Given this list of marker genes CYP3A4, BCOR, PCYT1A, SMOC1, ZBTB20, UFSP2, CTC1, ADGRV1, GNPTG, POLRMT, COL11A1, BMPR1B, ALG12, DNAJC30, GTF2IRD2, MAGEL2, KIF7, AFF4, CHD7, MAP2K2, PWAR1 (NCBI Gene Id 8122), IFT172, TMEM270, SLC29A3, KIF22, NEPRO, RSPRY1, GAN (NCBI Gene Id 8139), TBL2, GORAB, TRAPPC2, SCN1B, ARSK, DMP1, SCN9A, PITX1, NOTCH2, PDGFRB, AFF3, SF3B2, TAF4, GTF2IRD1, KDELR2, CDC45, TAPT1, SLC34A3, CYP2R1, MMP13, SF3B4, FZD2, CHST3, LMOD3, CFL2, LRP5, EIF2AK3, CEP120, NEK1, NF1, CBS, SLC34A1, IPO8, H3-3B, PEPD, ORC1, MEG3, B3GAT3, RMRP, COL9A3, CANT1, ARCN1, KAT6A, IDUA, BMP4, CCDC47, AMER1, DYNC2I1, TTI1, TONSL, COL9A1, NSD1, GTF2I, WDR62, TNFSF11, CYP27B1, DDRGK1, PTH1R, LMX1B, SFRP4, OCRL, TBX15, ALPL, ANAPC1, EIF4H, PUS3, MET, NCF1, TRPV4, PDE4D, NKX3-2, STX1B, CRTAP, BRF1, COL1A1, FLNB, PRKG2, HEATR3, TRIP11, VPS13B, PLOD2, KLHL41, SPART, ZEB2, MTAP, SATB2, MEGF8, INPPL1, ZPR1, RTL1, RNU4ATAC, EN1, LTBP1, GABRA1, BAZ1B, ATP7A, KRAS, SERPINH1, SEMA3E, MAN2B1 (mannosidase alpha class 2B member 1), P3H1, TUBB3, SPTBN1, PWRN1, XYLT1, RAD21, FBN1, TMEM38B, SNORD116-1, FIBP, PRRT2, DYM, FGFR3, IFIH1, TGFB1, CCN2, NDUFAF6, GLI3, RB1, NPAP1, SLC10A7, SNORD115-1 (NCBI Gene Id 338433), ARSB, BGN, BUD23, TGDS, TNFRSF11B, ENPP1, COL10A1, DLK1, IFT57, IDH2, TBXAS1, CLCN5, CYP19A1, DDX6, GDF5, SLC35D1, VPS37D, PRKACB, TNFRSF11A, GABRD, TP53, PCDH19, GLI1, CPLANE1, PRR12, LIMK1, ACTB, B3GALT6, MBTPS2, DONSON, RFC2, GLB1 (NCBI Gene Id 2720), COG5, COL9A2, EXT1, NEK9, SLC26A2, GUSB, HYLS1, TPM2, INTU, ATR, LMBR1, RAB33B, DDR2, EVC2, SKI, TRPV6, EIF4A3, ELN, PLAAT3, TENT5A, UGP2, LBR, TRPS1, PHEX, TBC1D7, PAPSS2, CBFB, IHH, PCNT, BHLHA9, IARS2, SGMS2, DYNC2H1, LAMA5, HS6ST1, NANS, AIFM1, HCN1, SCN2A, RBM8A, SOX9, MTX2, IFT122, MPZ, COG4, PAPPA2, COL1A2, ADNP, HSPG2, CLCN7, ORC6, SHH, COL2A1, GALNS, CTNS, SP7, ZSWIM6, BPNT2, GABRG2, SLCO2A1, SCARF2, NEB, SETBP1, CAMK2A, EFL1, MCTP2, COMP, RPL13 (NCBI Gene Id 6137), LONP1, MAP2K1, GPX4, NAA60, ZNF699, SLC35A2, POLR3A, MKRN3, FN1, POLR1A, RECQL4, DYNC2LI1, GPC6, WNT7A, CCN6, CSGALNACT1, CLIP2, CILK1, TCTN3, CTCF, HS2ST1, FGFR2, CHEK2, RPGRIP1L, MATN3, FGF23, POR, ACP5, CENPT, PMP22, EXT2, PRKAR1A, SCN1A, MAPK8IP3, EVC, EHHADH, PRKACA, ATRX, FKBP6, METTL27, SERPINF1, CLTCL1, BMP1, NEK8, CYP27A1, P4HTM, BRAF, FLNA, CLDN16, HBB, PHLDB1 (NCBI Gene Id 23187), HERC2, ACAN, IDH1, RUNX2, SHOX, TFE3, HPGD, MMP9, ACTA1, RAB23, LIFR, SLC31A1, FGF13, VDR, STX1A (NCBI Gene Id 6804), COL11A2, here is a description of the gene set: studied in species Homo sapiens Human Gene Set: HP_ABNORMALITY_OF_THE_CALF Abnormality of the calf An abnormality of the calf, i.e. of the posterior part of the lower leg.